The following is a description of a gene set: Mouse Gene Set: REACTOME_POLYMERASE_SWITCHING_ON_THE_C_STRAND_OF_THE_TELOMERE studied in species Mus musculus Polymerase switching on the C-strand of the telomere, and this is the list of marker genes: Ctc1, Rfc3, Pold2 (NCBI Gene Id 18972), Ten1, Pold3, Stn1 (NCBI Gene Id 69648), Pold1, Rfc4, Pola2, Pcna, Chtf18, Acd, Rfc5, Rfc2, Pola1, Dscc1, Terf2ip, Prim2, Chtf8, Prim1, Pold4, Terf1, Terf2, Rfc1, Pot1a